Given this list of marker genes UBE2B, RPL29, SORBS3 (NCBI Gene Id 10174), RPL34, RANBP2, CD247, TAFAZZIN, NUCB2, TERF1, RPS28, ITPKB, SNRK, SARAF, HDAC5, DAZAP2, EIF4A2, EPHB6, GAB2, PPM1H, TCF7, TUBA1A, IGLV3-25, TSN, SGK1, PCNX2, RPS8, SYNE2, MCF2L, MT2A, MNT, SDCBP, MT1H, BTN3A1, RGS10, CYTH1, RBM38, SEC14L2, HNRNPDL, PAN2, CYFIP2, ADD3, DDIT3, PLA2G6, PFDN5, SH3YL1, TGFBR2, SERPINB7, GADD45A, H1-4, CREM, HNRNPH2, EXTL3, RPL28, RPL13, CDC42BPA (NCBI Gene Id 9876), JUND, LGALS8, SENP6 (NCBI Gene Id 26054), PRKCQ, CCNI, RPS15A, TRIO, TRAM2, AREG, TXNIP, PIK3IP1, TLR1, FAM168A, TLE5, BTG1, LEPROTL1, KAT2A, RPS17, CLEC2B, SETD1B, PPP6R2, HEXIM1, TDRD3, MID2, RPS27A (ribosomal protein S27a), RPS29, LTB, LRP10, DNAJB2, CASP4, FCMR, ITGA6, AMT, CCR7, ATP6V1G1, RPL11, TMEM131L, JUNB (JunB proto-oncogene, AP-1 transcription factor subunit), RPL10, TSC22D2, RBL2, TPM2, BICRAL, GADD45B (growth arrest and DNA damage inducible beta), PDE4B (NCBI Gene Id 5142), RPL22, MAL, OS9, ARHGEF18, NR2C2, AUTS2, GAD2, ADA, BBIP1, SERPINF1, SRSF6, PAX6, MINDY2, PPT2, IL7R, ITGA2B, FOXN3, SPAG9, PPP1R15A, CASQ2, UBXN1, RPS13 (NCBI Gene Id 6207), CIRBP, MXI1, STX16, APOB, IFITM1, ADCY9, RPL32, RPS23, RGS1, STX3, EIF3G, PCNX1, LAMP1, KAT7 (lysine acetyltransferase 7), ENC1, MAN2B2, RPL38, ARL4C, RASA3, CLSTN1, SGSM2, PLCD1, DGKZ, TBX19, IFI44, BCL11A (BCL11 transcription factor A), RPS12, KLF5, TSC22D3 (TSC22 domain family member 3), HLA-E, NME3, AKAP17A, RPL37, TOX, VPS9D1, PER1, BNIP2, TIPARP, RALYL, FCHSD2, OCRL, DDX3X, JOSD1, FCGRT, SORL1, RNF139, PPARD, UBA7, MZF1, LEPROT, CTSW, ST3GAL6, TENM1, GTPBP6, RPS20, ARL2BP, LGALS3BP, RPL30, BTG2, DNAJB6, ICOS, NLRP1, FGFR1, MAD1L1, PRKACG, CCT6B, ITGB8, USP15, RPL31, ACVR2A, TPT1, IL11RA (NCBI Gene Id 3590), GABARAPL1, RBM39, HBEGF, SC5D (sterol-C5-desaturase), ZFP36L2, here is a description of the gene set: Genes up-regulated in thymocytes: double positive versus CD4 single positive. Human Gene Set: GSE26156_DOUBLE_POSITIVE_VS_CD4_SINGLE_POSITIVE_THYMOCYTE_UP Gene expression of Double Positive, and Single Positive CD4+ human thymocytes from publication Ghisi M, Corradin A, Basso K, Frasson C, Serafin V, Mukherjee S, Mussolin L, Ruggero K, Bonanno L, Guffanti A, De Bellis G, Gerosa G, Stellin G, D'Agostino DM, Basso G, Bronte V, Indraccolo S, Amadori A, Zanovello P (PMID 21551231) species: Homo sapiens